The following is a description of a gene set: Any process that stops, prevents or reduces the frequency, rate or extent of intrinsic apoptotic signaling pathway by p53 class mediator. studied in species Mus musculus Mouse Gene Set: GOBP_NEGATIVE_REGULATION_OF_INTRINSIC_APOPTOTIC_SIGNALING_PATHWAY_BY_P53_CLASS_MEDIATOR, and this is the list of marker genes: Muc1, Marchf7, Sh3glb1, Armc10, Mdm2, Prkn, Bcl2l12, Bdkrb2, Mif, Sirt1, Kdm1a, Mdm4, Pttg1ip, Zfp385a, Atad5, Rrm2b, Cd74, Cep63, Cd44, Rrn3, Triap1, Ell3